The following is a description of a gene set: Alveolar rhabdomyosarcomas (ARMS) are aggressive soft-tissue sarcomas affecting children and young adults. Most ARMS tumors express the PAX3-FKHR or PAX7-FKHR (PAX-FKHR) fusion genes resulting from the t(2;13) or t(1;13) chromosomal translocations, respectively. However, up to 25% of ARMS tumors are fusion negative, making it unclear whether ARMS represent a single disease or multiple clinical and biological entities with a common phenotype. To test to what extent PAX-FKHR determine class and behavior of ARMS, we used oligonucleotide microarray expression profiling on 139 primary rhabdomyosarcoma tumors and an in vitro model. We found that ARMS tumors expressing either PAX-FKHR gene share a common expression profile distinct from fusion-negative ARMS and from the other rhabdomyosarcoma variants. We also observed that PAX-FKHR expression above a minimum level is necessary for the detection of this expression profile. Using an ectopic PAX3-FKHR and PAX7-FKHR expression model, we identified an expression signature regulated by PAX-FKHR that is specific to PAX-FKHR-positive ARMS tumors. Data mining for functional annotations of signature genes suggested a role for PAX-FKHR in regulating ARMS proliferation and differentiation. Cox regression modeling identified a subset of genes within the PAX-FKHR expression signature that segregated ARMS patients into three risk groups with 5-year overall survival estimates of 7%, 48%, and 93%. These prognostic classes were independent of conventional clinical risk factors. Our results show that PAX-FKHR dictate a specific expression signature that helps define the molecular phenotype of PAX-FKHR-positive ARMS tumors and, because it is linked with disease outcome in ARMS patients, determine tumor behavior. from publication Davicioni E, Finckenstein FG, Shahbazian V, Buckley JD, Triche TJ, Anderson MJ (PMID 16849537) studied in species Homo sapiens Genes down-regulated in mARMS (molecular ARMS) compared to the mERMS (molecular ERMS) class of rhabdomyosarcoma tumors. Human Gene Set: DAVICIONI_MOLECULAR_ARMS_VS_ERMS_DN, and this is the list of marker genes: DUSP7, DUSP4, COL5A2, TRPS1 (transcriptional repressor GATA binding 1), TRIL, CHMP7, RGS10, RGL1, TNFRSF1A, FABP5, GFUS, MAGEL2, OLFML3, ARL4A, FZD4, KCTD12, MFAP4, TRIP6, ITM2A, SIGIRR, CTDSPL, GALNT2, MYF5, RRBP1, FAT4, ZNF16 (NCBI Gene Id 7564), NCOA2, AMPD2, NYNRIN, LINC00963, TRIB2, EXOSC4, OBSL1, OPLAH, EIF4EBP1, NRXN2, LAMA2, PLAG1, EVA1B, FZD7, FNDC3B, KAZALD1, HOXC6, GMPPA, FBN2, TSKU, SCARA3, CACNA1G, LY6E (NCBI Gene Id 7999), LHX6, PTPN13, STEAP1, RAB32, EHD1, TRIP10, EFEMP2, FHIP2B, CREB3L1, DOK1, TSSC4, PTGER4, PRR16, EMP3, P3H3, FBLN1, SOBP, CCND1, HIF3A, BMP1, SLC1A3, PLBD1, TRAPPC9, PVALB, HEY1, CPM, SORBS3, NBN, OCA2, EXT1, CDC42EP4, CITED1, TSPAN9, HMGA2, SMCO4, GAREM1, PRAME, RBMS3, APLP2, PGRMC1, ADGRL1 (NCBI Gene Id 79732), OLFML1, TPBG, GLT8D2, BMP4, BST2, PSD3, GAS2, FKBP11, RHBDF1, SLC52A2, EEF1D, PDGFRL, GSTM1, GULP1, DENND1A, LPAR1, AKIP1, WLS, SEMA3B, FAM110B, CSRNP3, SOSTDC1, P3H4, NAV3, CRABP2, CRTAP, RHOG, IGF2BP2, PMP22, NUAK1, ADA, MAPKAPK3, DLC1, PLPP3, NIBAN1, PLK2 (polo like kinase 2), NNAT, CYP26B1, HOXC11 (NCBI Gene Id 3227), MGAT1, TMEM45A, ITM2C, CNNM4, PTN, ERBB2, MMP2, CD248, ERF, ISLR, SH3BP5 (SH3 domain binding protein 5), DENND2A, SNCAIP, SLC43A3, HOXC10, BOP1, IER2, MFAP2, PTP4A3, EMILIN1, PTH1R, SLC1A5, TP63, EPHB3, WNT11, HOXA10, ADGRE5, LTBP4, ZFP36L2, KHNYN, GPC4, EPHB4, SLC39A4, ASAP3, C1orf54, GPAA1, REEP4, CCDC25, ZIC1, INPP4B, ADGRA2, KAZN, SERPINH1, ZFHX4, COLEC12, ARHGEF40, SLC39A14, PARVA, SDC1, EGFR